The following is a description of a gene set: The chemical reactions and pathways resulting in the breakdown of glycosaminoglycans, any one of a group of linear polysaccharides composed of repeating disaccharide units. Mouse Gene Set: GOBP_GLYCOSAMINOGLYCAN_CATABOLIC_PROCESS species: Mus musculus, and this is the list of marker genes: Hexb, Gusb (NCBI Gene Id 14929), Galns, Slc9a1 (NCBI Gene Id 20544), Sgsh, Hyal2, Pglyrp1, Hyal6, Cemip2, Pglyrp2, Pglyrp4, Stab2, Arsb, Cd44 (CD44 antigen), Lyg1, Hyal3, Fgf2, Hmmr, Ids, Hyal5, Lyve1, Idua, Spam1, Lyg2, Hyal4, Tgfb1, Hexa, Hyal1, Cemip, Pglyrp3